Given this list of marker genes ATIC, AMPD1, HPRT1, ADSS2, IMPDH1, XDH, PNP, DGUOK, PRPS1, ADSL, APRT, ADA, ITPA (inosine triphosphatase, NCBI Gene Id 89313), here is a description of the gene set: Human Gene Set: WP_PURINE_METABOLISM studied in species Homo sapiens Purine metabolism